The following is a description of a gene set: Mouse Gene Set: GOBP_CARDIAC_MUSCLE_CELL_PROLIFERATION species: Mus musculus The expansion of a cardiac muscle cell population by cell division., and this is the list of marker genes: Tgfbr2, Gli1, Yap1, Cdk1, Fgfr2, Tgfbr1, Mapk1, Cited2, 2810429I04Rik, Tbx20, Smad1, Hey2, Prkar1a, Rbpj, Ctnnb1 (NCBI Gene Id 12387), Tbx2, Fgf2, Nog, Dipk2a, Apc, Foxc2 (forkhead box C2), Sav1, Cxadr, Myh10, Ccnb1, Tbx1, Rbp4, Gata4, Fes, Tenm4, Tgfbr3, Fgf20, Nkx2-5, Pim1, Mef2c, Kcnk2, Notch1, Bmpr1a, Rxra, Tbx5, Bmp10, Wnt2, Ccnd2, Abl1, Gja1, Mir133a-1, Fgfr1, Jarid2, Fgf1, Vgll4, Rxrb, Foxc1, Ncam1, Hdac2, Dyrk1a, Mapk14, Trp73, Mir133a-2, Erbb4, Tgfb2, Foxp1, Nrg1, Mir1a-2, Pten, Gata6, Ski, Fgf9, Arid2, Zfpm2, Mapk11